Given this list of marker genes CDKN3, HMGB2, CXCL12, MCM2, EZH2, FOXM1, MKI67, PCLAF, CCNA2, KIF11 (kinesin family member 11), TMSB15A, here is a description of the gene set: Hypermethylation of the promoters of cancer-related genes is often associated with their inactivation during tumorigenesis. Several preclinical and clinical trials have been developed to use DNA methylation inhibitors, such as 5-aza-2'-deoxycytidine (5-Aza-CdR) in attempts to reactivate silenced genes in human cancers. We used high-density oligonucleotide gene expression microarrays to examine the effects of 5-Aza-CdR treatment on human fibroblast cells (LD419) and a human bladder tumor cell line (T24). Data obtained 8 days after recovery from 5-Aza-CdR treatment showed that more genes were induced in tumorigenic cells (genes induced; >or=4-fold) than nontumorigenic cells (genes induced; >or= 4-fold). Approximately 60% of induced genes did not have CpG islands within their 5' regions, suggesting that some genes activated by 5-Aza-CdR may not result from the direct inhibition of promoter methylation. Interestingly, a high percentage of genes activated in both cell types belonged to the IFN signaling pathway, confirming data from other tumor cell types. Human Gene Set: LIANG_SILENCED_BY_METHYLATION_DN from publication Liang G, Gonzales FA, Jones PA, Orntoft TF, Thykjaer T (PMID 11861364) Genes down-regulated in LD419 cells (fibroblast) after treatment with decitabine (5-aza-2'-deoxycytidine). species: Homo sapiens